The following is a description of a gene set: Analysis of the transcriptional response to SARS-CoV-2 compared with other respiratory viruses, including MERS-CoV, SARS-CoV-1 (SARS), human parainfluenza virus 3 (HPIV3), respiratory syncytial virus (RSV), and IAV. from publication Blanco-Melo D, Nilsson-Payant BE, Liu WC, Uhl S, Hoagland D, Møller R, Jordan TX, Oishi K, Panis M, Sachs D, Wang TT, Schwartz RE, Lim JK, Albrecht RA, tenOever BR (PMID 32416070) Human Gene Set: BLANCO_MELO_COVID19_SARS_COV_2_INFECTION_A594_CELLS_UP Genes up-regulated in SARS-CoV-2 infection (A549 cells, MOI: 2, 24hpi) species: Homo sapiens, and this is the list of marker genes: TRIM36, SCG5, TIPARP, RPS6KA2, ALDH1L2, ANK2 (NCBI Gene Id 4028), MMP1, SPMAP2, BEX2, CDH3, N4BP3 (NCBI Gene Id 23138), SCN4A, SLC6A15, ZMIZ1-AS1, CRYBG1, SDR16C5, GAS5, DNAH17, RUNX2, CDCP1, IL1B, IL1A, RBMS3, MAP2, RASGRP2, AMPD3, IL6, EGOT, ICAM1, PCDH1, CHAC1, PTPRE, BMPER, PGM5P2, DDIT3, SPX, GBP4, BCAT1, ZMAT1, ABCA1 (ATP binding cassette subfamily A member 1), EREG, TMEM156, NDUFA4L2 (NCBI Gene Id 56901), SERPINB3 (NCBI Gene Id 96249), TSC22D3, CLEC4E, RAB39B, FUT1, CSF2, PTX3, FYN, ATF3, MTHFD2, SERPINB4, ECM2, PARP8, MMP10, BCL2A1, STC2, ZFAS1, ULBP1, EXPH5 (NCBI Gene Id 23086), ARRDC4, LAMC2, CXCL8, KCNQ3, OLR1, SLFN5, TNFRSF9, CFB, SERPINB7, GREM1 (NCBI Gene Id 7947), SNHG32, CCBE1, RASGRF2, C15orf48, INHBE, IL3RA (NCBI Gene Id 8281), ROCK1P1, TM6SF1 (transmembrane 6 superfamily member 1), HMGN2P46, ATP6V1C2, ADM2, CCL5 (C-C motif chemokine ligand 5), HSD11B1, TREM1